The following is a description of a gene set: Mouse Gene Set: GOCC_ASTER species: Mus musculus An array of microtubules emanating from a spindle pole MTOC that do not connect to kinetochores., and this is the list of marker genes: Dynlt3, Ccsap, Pafah1b1, Kif18b, Mapre1, Kif18a, Mapre3 (NCBI Gene Id 100732), Map9, Fam161a (family with sequence similarity 161, member A), Tpx2, Numa1, Misp